The following is a description of a gene set: Laryngotracheomalacia Human Gene Set: HP_LARYNGOTRACHEOMALACIA species: Homo sapiens, and this is the list of marker genes: EMC1, HK1, KIF22, COL2A1, FLNB, TRRAP, TONSL